The following is a description of a gene set: Human Gene Set: CACTTTG_MIR520G_MIR520H Genes having at least one occurence of the motif CACTTTG in their 3' untranslated region. The motif represents putative target (that is, seed match) of human mature miRNAs hsa-miR-520g and hsa-miR-520h (v7.1 miRBase). studied in species Homo sapiens, and this is the list of marker genes: SALL1, SEMA4C, PCDHA5, FASTK, EPAS1, NHLH1, USP12, EPHA5, SLC30A3, SMOC2, CELSR2, TRPS1, MIEN1, SLF2, DNM2, FLRT3, VLDLR, USP37, ITPRID2, OGA, CELSR3, PTK2B, CEP57, ZFAND3, CAMK2N1, CACUL1, EFL1, LIMK1, PLEKHM1, ARMC8, DPYSL5, SMAD7, MKNK1, SLC39A14, DMTF1, TCERG1, USP9X, PCDHA1, PLOD2 (NCBI Gene Id 5352), EIF4G2, CASP8, DAPK2, KMT5B, FBN2, TLE4, PCDHA10, NAA30, FOXO1, MAPK9 (mitogen-activated protein kinase 9), PCYT1B, CCDC73, CFL2, AFG1L, ARAP2, PCDHAC1, YPEL2, GOLGA7, LAMTOR5, GREB1L, TNFSF12, PFN2, PCDHA12, SPRY4, EIF4E, PRKAR2A, ZDHHC9, HMGB3, FURIN, TBL1X, ARL4C, ETS1, TNFSF11, DNAJB5, SPRED1, SORL1, NLK, GTF2IRD2, KPNA3, NR4A3, PCDHA11, JAZF1, TTN, TMEM168, ARID4B, CNR1, NPAS3, CHUK (NCBI Gene Id 1147), TRIM33, CMPK1, DNAJB6, FNDC3A, SS18L1, SET, UBE2W, UNKL, TNFAIP1, SENP1, BRD1 (bromodomain containing 1), SLC2A4RG, IGF2BP1, OTUD4, GRHL2, ENC1 (NCBI Gene Id 8507), SAMTOR, MAP3K9, CALU, SLC1A2, EPHB2, AJUBA (ajuba LIM protein), ZNF280B, PITX1, KHDRBS1, DMD, KPNA1, TP53INP1, ZC2HC1C, ATXN1, HOMEZ, SOCS6, RHOV, E2F1, DCAF8, KRT81, RUNX1, PPP3CA, MAPRE1, ADGRB2, HIF1A, NSD2, SERINC1, ATP2B2, VEGFA, CCNJ, MAP3K14, NBEA, MYCBP, HAPSTR1, MSANTD4, DYRK1A, MAT2A, MAGI2, TNRC6A, ZBTB1, PPP6C, SINHCAF, REM2, ABHD2, DHDDS, GRM7, RFX4, SATB2, PTPN13, ZBTB6, SLC6A9, CUL3, PCDHA7, SKI, PCDHA9, LINGO1, SLC2A3, ZBTB7A, SUMF1, TP53INP2, CKS1B, NR4A2, MIPOL1, PCDHA4, WDR1, EFNB1, THRA, APBB2, ZNF362, RNF145, POU4F2, RSPO2, PCDHA8, TNKS1BP1, AZIN1, ERI3, NEUROG2, PCDHA6, NIN, VPS26A, PCDHAC2, TBC1D9, AFF4, TRIM13, PRRX1, TMUB2 (NCBI Gene Id 79089), KLF12, FAM83D, FLRT2, AHCTF1, NCOA3 (NCBI Gene Id 8202), TFEB, ABCA1, CREBRF, RHO, DBN1, NPAS2, PLAGL2, RABGAP1, MARK4, NELL1, CCND2, PCDHA13, TRPC5, EBF3 (EBF transcription factor 3), TMTC2, LUC7L3, GBF1, MEF2D, TBKBP1, GTF2IRD2B, SMAD6, PAPOLG (NCBI Gene Id 64895), MYCN, CA10, DDX11, CBX2, FAM13B, ETF1, EMSY, PAFAH1B2, RUNX2, PLCB1, CIC, CDKN1A, TBX3, MACF1, ZFP91, PCDHA2, TGOLN2, PCDHA3, MAF1, CHD9, CSMD3, LHX8, PRICKLE2 (prickle planar cell polarity protein 2)